Given this list of marker genes Epha4, Ccnh (NCBI Gene Id 66671), Rabl3, Mfsd8, Lamp2, Tmc8, Sumo1, Hsp90ab1, Bag5, P3h1, Tyrobp, Frey1, Hsp90aa1, Hip1, Mtrr, Crebl2, Wiz, Creb1, Hspa1b, Stx12, Trim37, Ncor2, Ip6k2, Kdf1, Stk4, D7Ertd443e, Usp2, Zswim7, Cdk7, Kcnu1, Flot1, Flna, Dcaf11, Smo, Rps7, Smad3, Apbb2, Pex19, Usp13, H1f5, Wdr81, Cog7, Atp1b1, Nop53, Trim44, Apbb1, Syvn1 (synovial apoptosis inhibitor 1, synoviolin), Pdcl3, Ipo9, Bag2, Tmc6, Clu, Ncor1, A1cf, Abtb3, Rab21, Swsap1 (NCBI Gene Id 66962), Zfp207, Usp19, Ifi30, Mtmr9, Taf9, Chek2, Tcf3, Golga7, Dsc3, Akt2, Trp53, Mul1, Cog3, Tescl, Tmem88, Tspan1, Crtap, Saxo1, Dnaja3, Phb1, Tcp1, Stxbp4, Naa16, Per3, Park7, Rpl23, Bag3, Hps4, Bbof1, Ubr4, Mapk8ip3, Naa15, Otud3, Rtn4, Mfsd1, Ptges3, Usp33, Cct6a, Usp27x, Telo2, Pfn1, Dvl3, Gm715, Dnlz, Phb2, Ift80, Irgm2, Dsg1b, Stub1, Prkn, Igtp, Sppl2c, Gapdhrt2, Gapdh, Igf1, Rassf2 (NCBI Gene Id 99374), Hspd1, Paqr4, Pim1, Glmp, Cdkn2a, Nckap1, Plpp3, Csn3 (casein kappa), Ppib, Mcm8, Cct5, Usp9x, Atf7ip, Pim2, Cdc37, Calr, Efna1, Sav1, Sec16a (SEC16 homolog A, endoplasmic reticulum export factor), Atp1b2, Ctnnd1, Cct2, Ncln, Npm1, Get1, Aak1, Cct8, Gtpbp4, Lamp1, Irgm1, Hypk, Pik3r1, Cep63, Ufl1, Dvl1, Stxbp1 (syntaxin binding protein 1), Cct7, Pin1, Wfs1, Ank2, Trim39, Cryaa, Cd74, Tbrg1, Hip1r, Dsg1a, Pin1rt1, Marchf7, Apoa2, Cdc37l1, Wnt10b, Nlk, Flot2, Apoa1, Cct3, Rassf1, Ep300, Pfn2, Rpl11, Prkra, Gapdhrt, Smad7, Cct4, Ptges3-ps, Pex6, Tbl1x, Caml, Atp1b3, Tesc, Pdcd10, Mt3, Usp7, Tnip2, Morc3, Cryab, Stk3, Trex1, Rpl5, Bag1, Chp1, Usp36, Gnaq, Ube2b, Coa8, Bag4, Pyurf, Dubr, Ahsp, Tsc1, Dsg1c, Msx1, Hcfc1, Pink1, Fbxw7, Sox17, Naa30, Afm, Brinp1, Usp29, Pten, Rab3gap1, Sox4, Zbed3, Bag6, Gpihbp1, Pml, Grn, Cblc, Taf9b, here is a description of the gene set: Any process involved in maintaining the structure and integrity of a protein and preventing it from degradation or aggregation. studied in species Mus musculus Mouse Gene Set: GOBP_PROTEIN_STABILIZATION